Given this list of marker genes POLK, POLB, PTGES3, TEN1, ACD, PIF1, POLE4, TERT, POLG2, POLE2, POLQ, POLD3, TERC, POLN, CHRAC1, TERF1, TEFM, POLH, ERCC4, MCRS1, POLD4, POT1, TEP1 (telomerase associated protein 1), POLD1, POLM, DKC1, REV1, PCNA, PINX1, TERF2, POLE, PRIMPOL, POLL, POLG, POLE3, REV3L, DNTT, POLI, POLA1, here is a description of the gene set: Catalysis of the reaction: a 2'-deoxyribonucleoside 5'-triphosphate + DNA(n) = diphosphate + DNA(n+1). species: Homo sapiens Human Gene Set: GOMF_DNA_POLYMERASE_ACTIVITY